Given this list of marker genes PYCARD, AIDA, NPPA, DUSP7, LATS2, INCA1, CDK5RAP1, APC, PKIA, PAQR3, DUSP1, DEFB114, AGT, CD300A, TFAP4, RGS14, CDKN1B, PTPN22, STK38, CDK5RAP3, MEN1, LATS1, CDKN2A, APOE, DNAJA1, HIPK3, PTPRJ, RASIP1, MAPK8IP1 (NCBI Gene Id 9479), MACROH2A1, PRKCH, HEG1, LYN, GADD45A, ADIPOQ, PDCD4, SERPINB3, PTPN1, here is a description of the gene set: Any process that decreases the rate, frequency, or extent of protein serine/threonine kinase activity. studied in species Homo sapiens Human Gene Set: GOBP_NEGATIVE_REGULATION_OF_PROTEIN_SERINE_THREONINE_KINASE_ACTIVITY